Given this list of marker genes HMGCLL1 (NCBI Gene Id 54511), AACS, ACAT1, BDH1, HMGCL, BDH2, ACSS3 (acyl-CoA synthetase short chain family member 3), HMGCS2, here is a description of the gene set: In a healthy, well-nourished individual, the production of ketone bodies occurs at a relatively low rate. During periods of normal physiological responses to carbohydrate shortages, the liver increases the production of ketone bodies from acetyl-CoA generated from fatty acid oxidation. This allows heart and skeletal muscle to use ketone bodies as the primary source of energy, thereby preserving the limited glucose supply for use in brain tissue.<p>In untreated <i>diabetes mellitus</i>, a huge buildup of ketone bodies occurs due to an increase in fatty acid oxidation. The production of ketone bodies exceeds the ability of peripheral tissues to oxidize them, and results in lowering the pH of blood. Blood acidification is dangerous, chiefly as it impairs the ability of hemoglobin to bind oxygen.<p>Ketone body synthesis proceeds via the synthesis of ccetoacetic acid in three steps from acetyl CoA, followed by the reduction of acetoacetic acid to beta-hydroxybutyrate. In the body, these reactions occur in the mitochondria of liver cells. species: Homo sapiens part of: Ketone body metabolism Reactome Pathway: Synthesis of Ketone Bodies